Given this list of marker genes ANXA2P2, CCR8, STUB1, ITGAV, PAX1, PRR36, BGLAP, KCNJ12, PPP2R5D (protein phosphatase 2 regulatory subunit B'delta), ZNF721, PTPN3, MMP11, KRT75, H4C6, TMEM43, FSCN1, MYBPC3, MS4A6A, PSD4, CD47, CPLANE2, TMEM74B, SERPINA2, FDPS, ADRA1A, SARDH, SMR3B, PTGIS, HSPA12A, LIMCH1, KRTAP5-8, TTC23, CDK5RAP3, ARHGEF40, MAGI1, FGF2, SND1-IT1, CERS4, FOXP3, GJB5, SAC3D1, CDKL2, TPST2, HLA-K, GADD45A, ZNF142, MRPL28, HBQ1, HMGCS2, PLA2G6, MVK, HBE1, SPRY4, SSR2, KCNJ9, THBD, ANXA2, TIMM8A, POU4F3, OR2B2, ADAM18, SEC14L1, ESR1, GAS8, CITED1, C6orf47, FLNB (NCBI Gene Id 8413), EMP1, S1PR5, PARD6B (par-6 family cell polarity regulator beta), GPM6A (NCBI Gene Id 2823), TUBA1A, CCDC7, CAMK2A, SOX13, GPR4, MYH10, GPSM3, CYTH1, PRR5, ACE, NEFH, PPP1R2C, FGF4, PNLIPRP1, CAVIN1, LARGE1, INTS11, TCF7, DPP6, MYL4, NEUROD6, CRIM1, IRF7, CFAP298, AUTS2, HNRNPM, CD82, KIAA1614, ANXA1, DUSP1, ZNF771, JAM3, PNP, FGF6, CACNB1, RALB, PCDHB8, FOSB, LMAN1L, KCNQ3, BICDL1, PTMA, KLF2, SPTBN4 (spectrin beta, non-erythrocytic 4), ARL4C, CAMTA1, PRKAG2, SORBS3, B4GALT3, SYT12, KRT85, NKX3-1, SUSD4, PICK1, IL6R, SERPINC1, HAUS5, SYNGR3, RNASE6, DAPK2, PSMC3IP, YWHAH-AS1, YBX3, FMO6P, CACNA1I, GSTCD, MPPED2, GRPR, COPA, TCF12, BTN1A1, PPFIBP2, CACNB3, RRP12, HERC1, KANSL1L, LYPLA2, DAPP1, ARC, NEU3, IZUMO4, UBAP2L, OR1F2P, CAPN5, C22orf31, ALOX12P2, GSTM5, DAPK3, PTCD1, NEUROD1, DSG1, DOK2, NPPC, CHRM4, GAS1, SMYD3, FDFT1, ARHGEF28, CNGB3, HOPX, CSF1, GAREM1, CABYR, NLE1, TP53BP2, ARHGAP33, KCNN1, NUDCD3, UCP1, NKX3-2, SERTAD2, EGR4, CRTC1, RFX2, VIM, RAB11FIP1, DENND5B, STX2, EPB41L4A, KCNJ5, PRODH2, SPOUT1, KCNMB1, HR, ALPK3, here is a description of the gene set: Human Gene Set: GSE21033_CTRL_VS_POLYIC_STIM_DC_1H_UP from publication Olex AL, Hiltbold EM, Leng X, Fetrow JS (PMID 20682054) Genes up-regulated in bone marrow-derived dendritic cellstreated by poly(IC): 0h versus 1h. BACKGROUND: Dendritic cells (DC) play a central role in primary immune responses and become potent stimulators of the adaptive immune response after undergoing the critical process of maturation. Understanding the dynamics of DC maturation would provide key insights into this important process. Time course microarray experiments can provide unique insights into DC maturation dynamics. Replicate experiments are necessary to address the issues of experimental and biological variability. Statistical methods and averaging are often used to identify significant signals. Here a novel strategy for filtering of replicate time course microarray data, which identifies consistent signals between the replicates, is presented and applied to a DC time course microarray experiment. RESULTS: The temporal dynamics of DC maturation were studied by stimulating DC with poly(I:C) and following gene expression at 5 time points from 1 to 24 hours. The novel filtering strategy uses standard statistical and fold change techniques, along with the consistency of replicate temporal profiles, to identify those differentially expressed genes that were consistent in two biological replicate experiments. To address the issue of cluster reproducibility a consensus clustering method, which identifies clusters of genes whose expression varies consistently between replicates, was also developed and applied. Analysis of the resulting clusters revealed many known and novel characteristics of DC maturation, such as the up-regulation of specific immune response pathways. Intriguingly, more genes were down-regulated than up-regulated. Results identify a more comprehensive program of down-regulation, including many genes involved in protein synthesis, metabolism, and housekeeping needed for maintenance of cellular integrity and metabolism. CONCLUSIONS: The new filtering strategy emphasizes the importance of consistent and reproducible results when analyzing microarray data and utilizes consistency between replicate experiments as a criterion in both feature selection and clustering, without averaging or otherwise combining replicate data. Observation of a significant down-regulation program during DC maturation indicates that DC are preparing for cell death and provides a path to better understand the process. This new filtering strategy can be adapted for use in analyzing other large-scale time course data sets with replicates. studied in species Homo sapiens